Given this list of marker genes ST6GALNAC3, ST8SIA3, CTSA, NANS, GLB1, NEU4, ST6GALNAC5, ST6GALNAC6, ST3GAL5 (ST3 beta-galactoside alpha-2,3-sialyltransferase 5), ST6GALNAC2, ST3GAL4, NEU3, ST3GAL6, GNE, ST6GALNAC1, ST8SIA4, SLC17A5, ST3GAL1, ST8SIA2, ST8SIA5, NPL, ST3GAL3, ST6GAL2, ST8SIA6, ST6GALNAC4, NANP, ST6GAL1, CMAS, NEU2, ST8SIA1, ST3GAL2, SLC35A1, NEU1, here is a description of the gene set: species: Homo sapiens Sialic acids are a family of 9 carbon alpha-keto acids that are usually present in the non reducing terminal of glycoconjuates on the cell surface of eukaryotic cells. These sialylated conjugates play important roles in cell recognition and signaling, neuronal development, cancer metastasis and bacterial or viral infection. More than 50 forms of sialic acid are found in nature, the most abundant being N-acetylneuraminic acid (Neu5Ac, N-acetylneuraminate) (Li & Chen 2012, Wickramasinghe & Medrano 2011). The steps below describe the biosynthesis, transport, utilization and degradation of Neu5Ac in humans. Reactome Pathway: Sialic acid metabolism part of: Synthesis of substrates in N-glycan biosythesis